Given this list of marker genes Il21, Gata3, Ecm1, Il2, Timm50, here is a description of the gene set: studied in species Mus musculus Binding to an interleukin-2 receptor. Mouse Gene Set: GOMF_INTERLEUKIN_2_RECEPTOR_BINDING